Given this list of marker genes RPS27A, TRIM27, B2M, HGS, PGK1, SNAP25, MRC1, SH3GL3, KPNB1, DUSP16, STX1B, ATP6V1H, TXNRD1, CTNNB1, STX1A, EPS15, EEF2, STAM, ANTXR1, GSK3A, NOS2, SH3KBP1, RNF213, MAP2K2, FURIN, MAP2K3, RAB5A, SH3GL2, CBLL1, CORO1A, SYT1, TLR2, LTF (NCBI Gene Id 4057), CTSG, UBB, GRB2, VPS33B, UBC, PDCD6IP (NCBI Gene Id 245794), CD9, VAMP2, SYT2, VAMP1, MAPK1, CALM1, CTNND1, MAP2K7, MAPK3, MET, STAM2, HBEGF, UBA52, ENO1, MAP2K6, HSP90AB1, SFPQ (splicing factor proline and glutamine rich), CDH1, MAP2K4, HSP90AA1, SH3GL1, CBL, SV2C, GUCY2C, SV2B, SRC, NHERF4, MAP2K1, SV2A, KPNA1, ANTXR2, RAB7A, here is a description of the gene set: studied in species Homo sapiens Bacterial Infection Pathways Human Gene Set: REACTOME_BACTERIAL_INFECTION_PATHWAYS